Given this list of marker genes Dkk3, Wnt4, Bmp2, Bmp5, Rest, H6pd, Dgkq, Cyp11b1, Cacna1h, here is a description of the gene set: studied in species Mus musculus The chemical reactions and pathways resulting in the formation of cortisol, the steroid hormone 11-beta-17,21-trihydroxypregn-4-ene-3,20-dione. Cortisol is synthesized from cholesterol in the adrenal gland and controls carbohydrate, fat and protein metabolism and has anti-inflammatory properties. Mouse Gene Set: GOBP_CORTISOL_BIOSYNTHETIC_PROCESS